Given this list of marker genes MT1X, MUC2, MT-CO1, APP, LOXL2, DAXX, ATP7B, CYP1A1, SOD1, PARK7, MT2A, MT1B, AQP1, MT1F, MAP1LC3A, NFE2L1, IL1A, MT4, MT1G, MT1A, CDK1, ATP7A, NFE2L2, AANAT, ATP5F1D, SNCA, LCAT, MT3, MT1DP, PRNP, MT1M, BECN1, BACE1, MT1E, HSF1, MT1HL1 (metallothionein 1H like 1), AQP2, MT1H, TFRC, MT-CYB, here is a description of the gene set: Human Gene Set: GOBP_RESPONSE_TO_COPPER_ION species: Homo sapiens Any process that results in a change in state or activity of a cell or an organism (in terms of movement, secretion, enzyme production, gene expression, etc.) as a result of a copper ion stimulus.